Given this list of marker genes RNF167, DEPP1, NACAP10, PLCG1-AS1, TPM2, RN7SL101P, CC2D1A, CARNMT1, FBXL2, LRIG3-DT, USP40, ZEB1-AS1, SLC47A2, SS18, ERP44, DRD4, ARIH2OS, EPN1, HSPA8, PRICKLE1, UVRAG, CAPN2, MAPK8IP3, KCNJ16, SNF8, COG8, SSR3, SNORD35A, UBXN6, RNU6-948P, MAP3K15, SNORD26, SMARCD3, RNU6-221P, BOLA3, CYP3A7, NDUFB9, PCNX1, ABCC11, GDI2, ZNF563, SLCO4A1, TNNT1, PPT2, ZNF668, AMOTL2, HSPB1, LINC00607, SRRT, MIR558, UACA, HES4, USP45, FASN, SLC35E4, ACOX2, ERCC5, TESPA1, DCTD, TRIM28, KRTAP13-3, HSP90AA1, C11orf97, PXDC1, SFTA2, C1QTNF12, SUGCT, NCOR2, RHBDD3, MTCO1P44, DM1-AS, PPP2R3B, EVI2A, MT-TF, RDH5, LEMD2, UBE2D3, METTL22, UQCC1, DUS2, LINC01355, LINC00837, ATRX (ATRX chromatin remodeler, NCBI Gene Id 6475), DGKZ, MRPL40, FRMD4B, TPI1, ARMC9, CIZ1, PTPRK, GET4, N4BP2L1, IFI16, RNF123, FGFR1, DNAI7, DOLPP1, SNAI2, MROH6, UBAP2L, SNORA80E, IL36A, ZNF580, ZNF516-AS1, ITPRID2-DT, HOXB6, USP37, RPL29P1, FOXD1, RNU7-140P, LINC00513, TRPC4, MIR623, COL16A1, NCK2, SNORD25, SNORA17A, ZNF584-DT, HOXD11, POLD2, SNORD49A, RPS21P7, TUBA1B-AS1, RRAS2, PROSER3, FSHR, STK17B, TMEM70, MAGI2-AS3, UBE2Q1, NMD3P2, PIK3R2, HGFAC, MVP-DT, HMGN2P13, TYW3, TRAPPC12 (NCBI Gene Id 51112), PRICKLE2-DT, MIR4748, ZNF148, ERLIN2, TOMM5, CEP170B, C1orf167, FADS1, THY1-AS1, ZNF971P, ANKRD28, RFX6, RAB11B-AS1, RPL9, MAP4K1, ZNF384, CSDE1, ASIC1, RASGRP3, C2CD2L, AGKP2 (NCBI Gene Id 392543), RTN2, SLC9A1, COL9A2 (collagen type IX alpha 2 chain), FASTKD5 (NCBI Gene Id 60493), TMEM253, NECTIN3, IER3, ENKUR, RNY4P6, SLC12A4, MEF2C, CRY1, EGFL6, FN1-DT, STAM, CCRL2, WRNIP1, BATF2, COQ10A, LNCOC1, POLR3G, VWCE, PHLDA1, TTC21A, F13A1, GREM1-AS1, RGS14, CCNL1, ANO3, GLIS1, RSRC2 (NCBI Gene Id 65117), HSPA1L, GLP2R, MIR7845, TLN1, BOP1, MAP3K1, LINC03016, COL6A3, TMC2, ZC3H8, RN7SL820P, TMEM50B, SMC3, ENO3, GPX2, MAPKAPK3, MIR5188, RNA5SP170, PSMB1 (NCBI Gene Id 5689), TRAPPC2L, PRSS23-AS1, TNS2 (tensin 2), RPL13A, ESYT3, ALDH3B1 (NCBI Gene Id 221), SPNS2, GIPR, RN7SKP52, CPEB4, TAGLN, SUPT5H (NCBI Gene Id 6829), TMEM132E-DT, ZFP91-CNTF, ITPR1, DUX4L35, CD300LB, CCDC47, H2AC20, KCTD20, LINC00649, SUPT4H1P2, CD68, COL8A1, FDPS, G2E3-AS1, MIR93, DSCR8, RNU6-1258P, DDB2, THOC6, GSK3B, TIMM17B (NCBI Gene Id 10245), SMAP2, GATA2-AS1 (GATA2 antisense RNA 1), LINC00331, ENSG00000225032, MIR130AHG, CASQ1, MMP17, EPB41L4A, ITGB1BP1, FRY, SCD, TPM3, OR6V1, RPL26L1, MMP10, ZNF207, ADAMTSL2, CPEB2, TUFT1, RGL2, WSB2, DNAJB14, WDR82, APEH, MTCO2P15, BHMT, SNORD34, SETD7, FRMD4A, NNMT, APOL3, ISG20L2, CTU2, CYGB, LINC02598, FOXO3, LINC02577, R3HCC1, STARD9, KPNA4, CDC25B, RPS17, FAM135B, JPT1, KBTBD2, LRP5, WSCD1, RUNX3, ARHGAP21, FCAR, TECR, ESCO2, ATP6V0D2, RNU4-18P, PALS2, ARL4AP5, SNORD50B, DNAJB8-AS1, NAT10, HINT3, RPL18, RPL12P7, ENSG00000252677, ELF1, SASH1, ZNF768, UNKL, DNAJB1, THNSL1 (NCBI Gene Id 79896), CLGN, INTS6-AS1, GMNN, NFE2L1-DT, FADS3, RMDN1 (regulator of microtubule dynamics 1), DPP3-DT, MKNK1, TAF10, ZNF638, MID1, AKT1, SLC20A2, HERPUD1, ENSG00000225647, ACVRL1, RPL13, PPT2-EGFL8, BIVM-ERCC5, MAPT-IT1, RDH10-AS1, NXNP1, AP3B2, RNF150, EEIG2, CDK13-DT, CELA3A, GPC1, RND3, SPTAN1, CFLAR-AS1, MRPL3, UBE2V1P5, ANKRD17, CBR3-AS1, CLDN15, SERPINH1, UPK1A, CASP8, SSR1, INKA1, CRACR2B, FOXO6, RRAGB, PLOD2, ZNF32-AS3, FGD4, NRN1, SMIM19, HSPB2-C11orf52, CIMIP6, RPS7P15, FAM174B, CAP1, RPL22P19, CLASP2, EDIL3, RAB33B-AS1, RPL21P126, PTPN3, SIK3, LOXL2, ENSG00000273523, PPP6R2, SUCLG2, PLEKHG1, MIR1226, MAGI1 (NCBI Gene Id 9223), MARVELD1, MBOAT7, CD22, ELOC, ATP10B, GRN, MMP25, PHF12, CFAP141, ST3GAL1, RGS17, MRPS22 (NCBI Gene Id 64953), OAZ2, ENSG00000227619, FAM184A, RNA5SP279, H1-9P, LRIG3, MIR141, DOC2GP, HRG-AS1, KLHL31, CORT, FBN1, HNRNPA0, IGDCC3, CLTC, ANKRD53, TGIF1, GLG1, SNAI3-AS1, RBM4B, STX18, MIR34AHG, SLC35F5, ENSG00000273828, EEF1D, UGCG, RBM14, SRP68, GAPDH, EOLA2-DT, GAB2, MTR (NCBI Gene Id 4548), GLYR1, LINC01521, MIR137HG, UBA1, GSTA4, C1QBP, AVEN, HNRNPUL1, NHEJ1, RFPL1S, KMT2E, SGSM3, ARPP19, OPA1, RN7SL148P, NRIP3, TNS1, PSMC6, CALD1, THBS1, TRADD, MXI1, PRRC2A, HSPB6, EXTL1, TBC1D14, ADD1, PTPN23, INTS6, DHPS, ZNF358 (NCBI Gene Id 55136), ERAP2, EFEMP2, TARS1-DT, RNF103 (ring finger protein 103), C9orf153, TRPM7, VPS37B, CLP1, VGLL4, TESK2, C19orf38, EPB41L1, ATP5MGL, MND1, MOCS2, DZIP1, ZNF226, NDUFS3, SNORD36B, LAMTOR4, ANKRD19P, RRP36, KRT78, PFDN2, IGHV5-51, DOCK1, MAU2, RGMB, NT5E, LINC03028 (NCBI Gene Id 101929117), SUCLA2, MIR604, FAM216A, ANXA9, EEF1A1P12, KREMEN2, LMAN2L, DGAT1, PPM1N, NALCN, CASQ2, EHBP1-AS1, ISG15, KIF9, CEACAM16, JUNB, PNPLA3, CCDC97, AGAP1 (ArfGAP with GTPase domain, ankyrin repeat and PH domain 1), DHRS4-AS1, FRMD6, MARCHF4, FTSJ3, PHC3 (polyhomeotic homolog 3), ACOT7, ABCA5, TMEM108 (transmembrane protein 108), ESRRB, CNGB3, RN7SKP116, HNRNPA1, ZSCAN26 (zinc finger and SCAN domain containing 26), LINC02550, SYNE2, IGLV3-21, LINC02790, DDX56, SEPTIN2 (septin 2), FAAP20, MIR4434, DIS3L2, RNU4-73P, TRPS1-AS1 (TRPS1 antisense RNA 1), TMEM123, DCAF6, MIR3973, RPL7P20, RBM20, UBE2I, CX3CL1, CAD, MYLK, C2orf88, TRIM4, MTFR1L, HGS, UBE2SP1, VOPP1, IER3-AS1, H2AC6, SETDB1, SNX18, PSMD11, MZB1, ATM, FGGY, EXOSC7, TUSC2, SIPA1L3, BMP6, TMEM38A, PPP2R3C, CELF2, INTS10 (NCBI Gene Id 55174), MIR133A1HG, BEX4, BTG1, NETO1, ETS1, MIR4470, MIR6131, DENND4B, CRYAB, GTPBP6, ITGA3, PPP1R3E, CREB3L4, HDX, MIR579, APBB3, HAS3, SNORD2, SMOX, DAPK1 (death associated protein kinase 1), FTL, SPRED3, IGFL2-AS1, ZNF582-DT, ZEB2, EFHC2, MYL6B-AS1, ARHGAP5-AS1, ZDHHC8, UBOX5, CHRNB1, EMC6, PPIAP54, CAV1, TMED1, MYO1D, ACSF2 (acyl-CoA synthetase family member 2), STK10, MTATP6P15, CNTNAP2, SRRM2-AS1, DCBLD1, NAT1, DBN1, TLCD2, H2AC10P, BRD1, LZTR1, ITIH4, RAB18, FNDC9, WNT7B, SORL1, FGF13, ZDHHC15, RFTN1, C11orf98P1, CCDC106, UBP1, BORCS8P1, FOXK2, SUN2, ORC4, SRPK1, NOL6, MIXL1, INPP4A, CLASP1, PACS2, NETO1-DT, REG1B, PLG, LEF1-AS1, BRME1, STAT3, ZYX, ZNF146, AGBL5-AS1, RBM22, MAP4K3, INTS13, DLGAP3, EXOC3, FAM167B, BRD2, GCN1, KDM3A, MAPRE3, ADIPOR1, LINC00472 (long intergenic non-protein coding RNA 472), LINC01584, LINC00968, PPT1, PLA2G6, ZNF337-AS1, FH, DOK7 (NCBI Gene Id 619409), AGBL5, ZNF571-AS1, RPS16P9, MIR3188, ALOXE3, MIR6892, WDR74, GNL1, BOLA3-DT, MPC2, FRG2C, L3HYPDH, EHMT1, NUBPL, ALG13, THUMPD3-AS1, ANKRD52, SPACA6, COQ3, SNORA17B, SNORD68, GABPB1-AS1, RNU6-658P, TSTD2, UTP18, PNLIPRP1, COG1, DLGAP1, TOMM20, KCNQ4, SRD5A3-AS1, CCDC85B, MKLN1, STRADA, NOL3, EPB41L2, SNORD24, VPS26C, DAZAP2, LINC01220, GRIA2, TMEM40, CD82, MYL11, MT2A (NCBI Gene Id 4502), H4C1, DNM3OS, MAPRE3-AS1, RIC8A, SNORD95, POU5F1P5, HOOK2, PTPA, SPAG17, BNIP3, MED28-DT, TECRL, ABCB6, DLG2, TMEM91, SNORA73B, AFG2A, CYP1B1-AS1, ISCU, TMEM9, MYO1F, ZNF529, NEXMIF, BIVM, NAGK, MIR1252, MORC2, ACTBP14, MYO3A, SPINK7, TINAGL1, TWNK, LINC02264, GLI2, ESR1, PDGFRA, RNA5SP326, MSTN, ZNF566, RNU5A-6P, YLPM1 (NCBI Gene Id 56252), KLF9, JRK, FLOT1, IDI1, SMIM7, TMEM69, TSEN34, RPL39P14 (NCBI Gene Id 100132127), TMBIM6, C1QTNF1, SNHG1, PPIEL, INHBE, PLAT, DYNC1I1, ELF2, TRIM41, MIRLET7I, NOP16 (NOP16 nucleolar protein), SNORD19B, AURKAIP1, TCP11L1, PSME3, GPR17, AAMP, KDM2B, KCTD11, SNORA24, BEAN1, EIF4A1, TRBV1, THBS2, DBP, LINC01920, BUB1B, ENSG00000227066, RPL7A, SLC22A31, MYO19, RTN4, ACAT2 (acetyl-CoA acetyltransferase 2), GPT2, GAS5, EEF2, RNU6-1231P, SELENOW, TUBB, JMJD8, SINHCAF, SNHG14, NCKAP1, CIB2, MIR3619, CHI3L2, USP3, IRX5, ENSG00000228771, MARCHF6, GPAA1, SLC16A6 (solute carrier family 16 member 6), CTBP2P1, RNU6-239P, RELT, CDH23, AQP4, RNU6-26P, HSPB2, PYCR1-AS1, NME9, MTCO1P31, PIPOX, PLPP5, SGK1, ZNF649, PHF23, JKAMP, ARFGAP2, ACTG1, SOD3, LSAMP, FBXW4, MAT2B, PPFIBP2, MIR125B1, CCDC107, H2AC12, LINC02629, MT-RNR1 (NCBI Gene Id 4549), ARHGAP15, EPN2, PAM, RNU2-43P, CYTH1, KLHL18, PIGP, TMEM259, MAZ, SHF, PREPL, MIR762HG, NTM, PCBP3, NFE2L1, LACTB2-AS1, PER1, POU2AF3, RASSF10-DT, RPS6KA2, LVRN, TTC28, MVK, CHTOP, MINK1, RPL36, LINC02283, HENMT1, MIR3120, CDRT15P5 (CDRT15 pseudogene 5), HR, SEPTIN11, KEAP1, LINC02355, CRYBA4, PITPNM1, MDS2, OSMR-DT, NMT2, HLA-DMA, INPPL1, ANKS3, NDUFB2, LINC02004, RNA5SP392, SIX5, LINC01501, ARL5AP1, INKA2, SLC38A2, SHARPIN, FADS2, TRGVA, MBTPS1-DT, COMMD6, AMPD3, CRNDE, FAM83E, NRDC, RGS3, FLCN, CDK9, MPP2, ZEB2-AS1, ARPC3P5, IFFO1 (intermediate filament family orphan 1), RPL26L1-AS1, CDKL5, PCBP4, LRP3, PNP, TPM1, INF2, YAE1, NPNT, BBIP1P1, UBTF (upstream binding transcription factor), RBM45, KCNK6, MDP1, PWWP3A, RPL8, RNU4-2, FOXN3, CCT7, P4HA2, RPS15A, TJAP1, GTF3C1, MAP2K7, RGS10, NTHL1, PHLDA1-DT, GLT8D2, USO1 (NCBI Gene Id 8615), RIPOR3, SKIL, PKP3, DOP1A, TMEM106A, EWSR1, ATP5F1E, CEP57L1, HSPA1A, EFNA1, CDK13, LIMS1-AS1, RIPOR1, TBC1D1, FASTK, TATDN1, NRXN1, MECOM, CYP4A27P, MYL4, MALAT1, CHD8, KLF7, DHX30, NAMPT-AS1, OGFOD1 (2-oxoglutarate and iron dependent oxygenase domain containing 1), ARRDC1, CYTH2, ZBTB4, UGP2, GPN2, KLF6, PLA2G4C, SNORD46, ZNF649-AS1, TRBV25OR9-2, PSKH2, ZNF391, FAM13C, EVI5L, CHMP2A, MAF, DNAJB5, CCNI, TM9SF1, VSIG10L, MTA1, GFM2, PCIF1, PTPRM, LCORL, GSK3B-DT, PLXNA4, DLGAP5, DUSP26, DNAJC16, PSMA7, CENPU, LHFPL2, SNHG8, CCAR2, ZNF500, MCM3AP, VAT1, CAGE1, DAPK3, H3-3B, AGPAT4, KRT18P54, RPS8, NUDT6, UGDH, SIAH1, SNN, GALNT14, RAPGEF3, MIR4270, CMSS1, ZFP90, ITGB5, ZNF516, ZNF24, MAPT-AS1, ENSG00000232448, PRRT3-AS1, NPLP1, SPEF2, ENSG00000227157, ZNF22-AS1, MYO5C, MAD2L1BP, PAK4, POLD4, GTPBP2, DAPK2, XPNPEP2, BZW1, DLGAP2, PDCD4, STXBP4, WRAP53, HAT1, UMOD, ENSG00000233581, SF3B2, P2RX6P, MCAT, PDLIM7, HDLBP, CSNK1D, JOSD1, RPL37P2, PAAF1, PIANP, RBM24, PQBP1, DLX2, SNORD65, CCN1, ING3, MIR222HG, TCTA, YBEY, PRKCH, THEM6, SNORA47, HINFP, SMURF2, WDR27, ZNF385B, MIR7111, RPL15P19, MYCNOS, PTPN4, RBM10, ANG, SNORA59B, LAT, CCNB1IP1P1, CCDC144NL-AS1, TUBB2B, MBTPS1, ENSG00000268460, ZBTB43, CHEK1, CAMK2D, MIR3130-2, TRIM59, GAS5-AS1, NDUFS7, ACTB, SIRT2, C1orf56, NEK2, TBCD (tubulin folding cofactor D), TRAF4, SNORD32A, CTHRC1, KAT14 (NCBI Gene Id 96680), LDLRAP1, WEE2-AS1, LINC01475, LINC01256, ACTG1P9, MTND1P15, NACAD, CCDC88C, PRELID1, NID2, STC2, CD151, PCLO, TMEM120B, OR5P3, LRP1, CCDC12P1, CISH, ZCCHC13, MED28, PACRG-AS3, DST, IPO5, METTL25B, RIN1, TBC1D3P6, RPL24 (NCBI Gene Id 6152), MTMR12 (NCBI Gene Id 54545), RPL6, CBFA2T2, FGF12-AS1, PANK2, ATP2A1, FGF5, KPNA2P2, GATA2, LAMB2, PDAP1, PAXBP1, TMEM19, ZCCHC17, SNORD28, PHLDB1, THOC5, ENSG00000223834, RRAS, RNFT1, MED26, MTIF3, EIF2AK3-DT, DCLRE1C, SNORA81, CCND1, MTND1P4, CMTM5, ZNF653, TNNT2, ZNHIT2, ETV5, MYO10, SNORA33, ATP5F1A, MIR25, SMAD3, DCTN1, KBTBD4, ARHGAP23, PTPRJ, NR3C2, GOLIM4, CRIP2, PLEKHG5, MIR210, SAE1, OR10T1P, KCNC1, KTN1, LINC02739, ENSG00000260660, ACTA2, LMO3, INVS, MAP1LC3A, ZZZ3, RNF13, RNU6-65P, TRAPPC1, MAMDC4, PLSCR3, EPS8L1, SCAPER, GNAI1, COL13A1, PAF1, GIPC2 (GIPC PDZ domain containing family member 2), CYP3A7-CYP3A51P, BTG1-DT, RNA5SP425, CCNHP1, ADAMTS1, MTF1, RAB11A (NCBI Gene Id 8766), ZFYVE16, DKK3, KIDINS220, MICOS10P3, ATXN2L, CFB, LINC01929, PGRMC2, CPVL-AS2, SNORD33, ACOX3, MIR4669, ENSG00000233569, USP11, GALK1, MTNR1B (melatonin receptor 1B), LINC01774, RNF213, PAPOLA-DT (PAPOLA divergent transcript), GPRIN2, ATXN1-AS1, PDE5A, NTRK3, ABRAXAS1, MDC1, IRF2BP1, FMNL1, PPIAP59, NOXO1, FAM107B, STRIP1, CUTA, RSRP1, MPPED2, TMEM86A, ZIC1, SNORD116-10, HMGA2, NALF2, PATZ1, UBA5, PCBP1-AS1 (PCBP1 antisense RNA 1), ANTXR1 (ANTXR cell adhesion molecule 1), LINC00944, CEP170, MLLT6, ZEB1, ELAC2, SLC35G1, C10orf95-AS1 (NCBI Gene Id 100505761, C10orf95 antisense RNA 1), NUMBL, COL1A1, HIRA, ABHD6, SLAMF8, DPH5-DT, LAD1, HNRNPA1P64, USP36, S100A16, COMMD3, VCAN-AS1, BRWD1, LGALS8-AS1 (LGALS8 antisense RNA 1), CUX1, CORO1C, ENSG00000201316, UBN1, THOP1, PRELID3A, SNHG7, SNORA10, LEF1, TLCD3B, ERAP1, ATP11AUN, UBE2M, RN7SL45P, HTATSF1, LINC02112, ZNF446 (zinc finger protein 446), ATP6AP1L, ENSG00000237761, RBM39P1, KLF4, LINC02210, ACTC1, NME2, CAMTA1, G3BP1, SP3, RASSF10, HSF1, ZNF577 (zinc finger protein 577), TEAD3, MT-TP, CARD8, TRIP12, ZBTB37, RMC1, TNS2-AS1, DCBLD2, TAS2R1, ATF4, VTN, SESN2, CNTN2 (NCBI Gene Id 6900), RNA5SP531, GPBP1L1, PAWRP1, ZFAS1, TSKU, PPP1R1AP1, TBX2-AS1, PGAM2, FBXO44, VEZF1, RN7SL322P, E2F8, MRC2, SNORD58A, SLC25A30-AS1 (NCBI Gene Id 100874259), SPTBN5, CCNP, ANKRD10, SERTAD3 (SERTA domain containing 3), FBXO7, MIR100HG, CYCSP41, MAGED1, MAP3K10, ABCE1, C2CD2 (C2 calcium dependent domain containing 2), IQGAP1, RHOA, MMADHC, PTOV1, MIR6832, ATG16L1, CREB3, RARB, SIM2, STAM-DT, BBC3, WWC2, GARNL3, MIR22HG, PIGH, SNORA50C, EEF1A1, DHX36, ILF3, GPC1-AS1, OGT (O-linked N-acetylglucosamine (GlcNAc) transferase), TCF7L2, PENK, SLFN13, CRAT, TOMM22P5, SDC4, MAB21L4, TRABD2A, SRSF10, MIR9-1HG, MAGI2, DDX42, CAMSAP2, TM2D3, TRIM67, SPACA5, NEMP1, ZNF169, MUC12, PIK3R4, EHBP1 (EH domain binding protein 1), RNASE4, HERC1, IQCH-AS1, PRMT1, MIR222, MMS22L, ZNF879, TRAF3IP3, PDE1B, LRRC37A11P, SLC5A9, SEPSECS-AS1, DDX39A, FGFR1OP2, HCFC1R1, BNIPL, RCC2P8, DCAF7, MB, USP9X, PHKG2, ACTR3, ELP3, TLX3, SPAG9, H2BC5, C10orf55, CLASRP, TRIO, EIF4A2, CLCN2 (chloride voltage-gated channel 2), ST7L, CYP2W1, ST20 (suppressor of tumorigenicity 20), P3H3, AJUBA, MUSTN1, RNU6-301P, RPL21, SNORD14E, MIR196A2, MIR3130-1, PTPN23-DT, IDS, LINC01730, RNA5SP38, ITGA7, PAIP2, ITPRID2, DNHD1, CNGB1, SLC3A2, ADAMTS7P4, JUND, PBXIP1, NAMPT, MIR4794, RN7SKP4, FABP3 (NCBI Gene Id 337956), SLC35C2, GTF2F2, DEFB135, H2BC17, SEPTIN9, PENK-AS1 (PENK antisense RNA 1), SSC5D, ENSG00000245025, CCDC9B, KLHDC2, RNU6-1072P, SWSAP1, PHB1, NEAT1, PHC2, MIR6090, CRTC1, MTFR2P1, DNAI2, NFE2L2, CTPS1, RPL10, SNORD58B, FSIP2, DPEP1, LHFPL1, WBP2NL, FDX1P2, ADAMTSL4-AS1, RPL31, FAM25EP, PLP2, POLR2A (NCBI Gene Id 5430), WDR37, MED15, TTC7B, ATN1, CNKSR2, H3C11, CBLC, FOXN1, H2BC3, TLL2, LYZL6, ANKRD34C-AS1, PPP2R2D, BAGE2, RASSF4, FDXACB1, SLC25A13, WDR54, TUBB4B, BLCAP, ABCA7, NAB2, PARP1, LINC-PINT, LIPT2, PRSS2, CLCN3P1, GPN3, CCDC6, UBE2L3, TMEM132A, PRTN3, CDKN2B, GLRA4, RXRB (NCBI Gene Id 6257), UBE3B, TMEM132E, LINC03108, MSH4, DPY19L4P1, LINC00470, SPARC, BCL9L, PDCL2P1, C15orf61, LAMP1, MTCO2P32, SNORD116-15, PYCR1, PPIAP41, TRMU, RAB26, NANOS1, DYSF, LCE3A, SEMA6A (semaphorin 6A), ENSG00000202231, UBE2D3P2, CASC15, IP6K2, ATRIP, TTN-AS1, GAS6, RNU6-89P (NCBI Gene Id 106480550), RNF11P2, SCX, PSMD6-AS2, TRAF7, RN7SKP264, TXNDC8, SNORD27, STIM1, CEP250, MIR3692, KCNB1, NFATC3 (NCBI Gene Id 82543), TOM1L2, GADD45A, TBP, OSBP2, HBP1, ENSG00000277855, DEPDC4, TMCO1 (transmembrane and coiled-coil domains 1), LINC01465, FAM234A, RASSF8-AS1, OSCP1, RARG, SCN4A, EP400, CREBBP, RNU2-3P, NRP1, TCEA2, GRIK5, DDX4, XYLT1, KIAA1755, RABGGTA, CDHR18P, LINC00677, RN7SL520P, CNOT9, POLR2F, SNORA63, TOR2A (NCBI Gene Id 84633), EHMT2, ZIC4, CHST14, ENSG00000228395, SNHG10, ZNF603P, NFYA, SUCLG2-DT, DCTN2, ZC3H6, RPL17-C18orf32, PPME1, TNNI1, FIBP, ADD3 (NCBI Gene Id 121), CWC27, TLE4, RBBP5, SNORD60, RUNX2, HEG1, XPO1, DALRD3, PALMD, BPTF, WT1-AS, FBXO2, RAD23B, PAICSP7, CASD1 (CAS1 domain containing 1), ILVBL, TM7SF2 (NCBI Gene Id 7108, transmembrane 7 superfamily member 2), BORCS8, DYNC1LI1, VPS28, IFI35, FLNA, OARD1, CCL28, PTMA, SGK3, REN, VN1R46P, RN7SKP64, PGGT1B, NXF5 (nuclear RNA export factor 5), C10orf95, ALDOA, KIF1A, UBC, PRKAB1, CCR5AS, TRIM7-AS1, MIR221, NR4A2, SNX16, ATG9B, CIRBP (cold inducible RNA binding protein), ENSG00000232732, PMCH, EXOSC3, ANKRD17-DT, NDST1, HMGN1P12, ABCA15P, NFIC, PDPR, CELF2-AS2, ITGB2, ENOSF1, CEMP1, RPS23, OOSP1P1, TGFBI, EGLN2, ASB8, OSBPL11, BRSK1, SNORD100, NR2F6, CLEC12A, CLUAP1, KCNJ2, NFKBIB, MPDU1-AS1, LRRC37A5P, SHD, LPCAT4, KPNA2, PSMD2, GPT, SERHL2, C12orf57, NRXN2-AS1 (NCBI Gene Id 107984337, NRXN2 antisense RNA 1), CC2D2A, CLK1, LINC00963, MIR210HG, NUDT4 (NCBI Gene Id 57236), IGLVI-38, FRYL, RERE, FAM151A, HMGA1P8, HDAC9, LINC02709, CTSD, ZNF581, BZW1-AS1, ENSG00000266844, LINC00430, SCYL2, MAF1, TYSND1, MIR1273H, PRR3, OR51T1 (olfactory receptor family 51 subfamily T member 1), SEMA4A, ST20-MTHFS, PARL, EIF1, ARFIP1, AFAP1 (NCBI Gene Id 60312), LIF-AS2, MIR1238, BDH2, UBE2Q2, STAT6, ACACA, MATN1-AS1, FIG4, CBFB, NKX2-1, GALNS, LAMC1, ADGRG1, ME3, ZNF407, BNIP3P23, NDUFB11, MTSS1, RBM39, ICAM1, TMEM106B, RPL27A, LINC02432, PRXL2B, PAPOLA, ROPN1L-AS1, THRA, ZNF219, RAPGEFL1, ABCB1 (ATP binding cassette subfamily B member 1), GTF2F2P2, NEK2-DT, NBR1, C2, ZNF444 (NCBI Gene Id 55311), CIBAR2, LINC00523, EBLN1, HERC3, BMP7, GNAI2, RNU6-495P, LINC02434, POLR2G, EMC1, MYL6, FYN, COL1A2, AUTS2, SNORA63B, ST3GAL1-DT, DNAJB4, EED, MIR151A, HMCN2, PDK4, ARHGEF28, CFAP418, PPFIA2, RHOC, PLAU, MXRA8, MSI2, DDX12B, RPL17, MIR6853, PPP4R1, PGM5, MARS1, GTF3C3 (general transcription factor IIIC subunit 3), DMPK, GLRX2, RCC1, PEX5, MT1P3, URB1, DPP3, POLDIP3, LRRC74B, TRIM11, PPIAP39, LGALS8, ADORA1, DST-AS1, PACS1, ZKSCAN7, SPOUT1, EEF1A1P45, CTTN, YPEL4, RPL17P11, MYOM3, KCNAB2, PRKAR1A, SETD5, LTO1, PLEC, BTG2-DT, ZNF584, SNRNP40, RACK1, DNAJB6P8, LRSAM1, SNORD102, NABP2, PCSK9, HELZ2, HK1, ENSG00000253632, MYL12A, CPSF3, LIAS (lipoic acid synthetase), ZNF236, DPP8, ANAPC7, EDC4, CLPTM1L, ADD3-AS1, SIVA1, PDGFC, TNFAIP2, LRRC32, SPNS3, MPV17, EVPLL, TUBA5P, FREY1 (Frey regulator of sperm-oocyte fusion 1), CNTROB, CT70, HNRNPDL, HCFC2, TMED11P, BMERB1, OSBP, CARINH, PDE3A, PRSS53, TMEM199, UQCC6, IL12A, SYBU, ARHGEF9, SNORA73A, KLHL7, IL11, ADCY6-DT, MED22, CDK5RAP2, SCAND2P, TAMALIN, OVCH2, ATP5MC2, PRPF40A, PSRC1, RPSAP31, DENND2B, ACTL8, IMPDH2, ZSCAN30, FTSJ1, SEMA4G (NCBI Gene Id 57715), MPHOSPH6P1 (NCBI Gene Id 124903873), NEK10, PDXP, GRK5, BIN1, SNORA70, CBX1, KCNG2, ARID1A, MIR6807, RBM5, POT1 (protection of telomeres 1, NCBI Gene Id 25913), TCF4-AS1, STN1, HDHD3, BICDL1, LINC02205, SLC23A3, SSH3, DDX5, MTCO3P12, VPS13A-AS1, KLHL7-DT, ITGB4, PCSK7, RNA5SP258, ZNF329, TP53, ZNF362, PPIG, PHYKPL, OBSL1, PABPC4, CTNNA2, AVIL (NCBI Gene Id 80056), MYH13, ZDHHC12, FAM193B, ZSCAN16-AS1, EXOC5, RNU6-341P, NEDD4L, LENG8, CNBD2, SWT1, LINC00437, SPATA31G1, EZH1, CXCL8, URB1-AS1, VASP (NCBI Gene Id 7408), HDGF, IGLVI-68, LINC00334, ERVFRD-3, ACSL3P1, ARHGAP5, RAB24, DIABLO, DENND1B, OGG1, MARK3, LMNA, WNT1, MYH9, ASXL1, RN7SL525P, RP9, CDH1, VTI1B, SET, PRAM1, ZC3H7A, ANXA2, BRD3, ATG4D, TMSB4X, VSIG10L-AS1, CSNK1G2, RN7SL862P, SPMIP3, GSTT4, SPRY1, PDCD6, CEP95, STRN4, CELSR1, NINJ1, ROPN1L, C2orf92 (NCBI Gene Id 730797), FN1, MXRA7, KNTC1, ACAP3, ZNF582, ZFAT, PDE4A, RPL30P14, PPIAP32, ATP6V1G1P4, KCTD13, IL1RAPL1, GABPB1, ZNF408, DPF2, MBD6, C4BPA, PANK4, PUM1, DUX4L18, PNKD, JAKMIP3-AS1, VMP1, BAZ1A-AS1, CDC37L1-DT, ERRFI1-DT, TMEM221, PIN1-DT, RPL32P22, ANLN, COMMD3-BMI1, EPS8, PRELID3BP8, ANKRD40, SNHG5, MCF2, CCN6 (cellular communication network factor 6), MN1, ENSG00000274248, SNORA27, LINC02352, KRTAP2-4, LGALS1, POLR2C, SSBP4, SALL4P5, SMG6, ASGR1, UGDH-AS1, ARPP21, MIR8063, ELOCP31, LINC02079, PLIN3, here is a description of the gene set: Human Gene Set: SUPT16H_TARGET_GENES studied in species Homo sapiens Genes containing one or more binding sites for (SUPT16H) in their promoter regions (TSS -1000,+100 bp) as identified by GTRD version 20.06 ChIP-seq harmonization. from publication Yevshin I, Sharipov R, Kolmykov S, Kondrakhin Y, Kolpakov F (PMID 30445619)